The following is a description of a gene set: Interleukin-2 (IL-2) mediates cell cycle progression and antiapoptosis in human T cells via several signal transduction pathways. The Tax protein of the human T-cell leukemia virus type I (HTLV-1) deregulates cell growth and alters the role of IL-2 in infected cells. However, Tax-immortalized cells stay dependent on IL-2, suggesting that events besides HTLV-1 gene expression are required for leukemia to develop. Here, IL-2-dependent and -independent events were analysed in a human T cell line immortalized by Tax. These studies show that, of the signaling pathways evaluated, only STAT5 remains dependent. Microarray analyses revealed several genes, including il-5, il-9 and il-13, are uniquely upregulated by IL-2 in the presence of Tax. Bioinformatics and supporting molecular biology show that some of these genes are STAT5 targets, explaining their IL-2 upregulation. These results suggest that IL-2 and viral proteins work together to induce gene expression, promoting the hypothesis that deregulation via the constitutive activation of STAT5 may lead to the IL-2-independent phenotype of HTLV-1-transformed cells. from publication Fung MM, Chu YL, Fink JL, Wallace A, McGuire KL (PMID 15735688) Genes up-regulated by IL2 in T1 cells (primary thymocytes immortalized by Tax, an HTLV-1 encoded gene). Human Gene Set: FUNG_IL2_SIGNALING_2 species: Homo sapiens, and this is the list of marker genes: CARD9, DDX21, ZBED2 (zinc finger BED-type containing 2), TNFRSF11B, IL9, MYC (MYC proto-oncogene, bHLH transcription factor), IRF4, IL13, SLC30A1, IL5, CCL3, CCR6